Given this list of marker genes JAK2, STAT3, IL12B, TYK2, IL12RB1, IL23R, IL12A, STAT4, IL23A (interleukin 23 subunit alpha), IL12RB2 (interleukin 12 receptor subunit beta 2), here is a description of the gene set: studied in species Homo sapiens Human Gene Set: KEGG_MEDICUS_REFERENCE_IL12_23_TO_JAK_STAT_SIGNALING_PATHWAY IL12/23 to Jak-STAT signaling pathway. Pathway ID: N01557. Pathway type: Reference. Pathway class: nt06518 JAK-STAT signaling. Pathway Definition from KEGG: (IL12,IL23A) -> ((IL12RB1+IL12RB2),(IL12RB1+IL23R)) -> (JAK2+TYK2) -> (STAT3,STAT4)